Given this list of marker genes FAT3, LARGE1, SLC1A1, ATP8A2, TFAP2A (NCBI Gene Id 95131), RDH13, FJX1, PTPRM, LHX1, SDK2, RS1, FOXN4, AHI1, SDK1, HIPK2, CALB1, MEGF11, CRB1, TFAP2B, DSCAM, HIPK1 (NCBI Gene Id 23323), PROM1, PTF1A, ARL6, TSPAN12, NDP, here is a description of the gene set: species: Homo sapiens Human Gene Set: GOBP_RETINA_LAYER_FORMATION The process in which the vertebrate retina is organized into three laminae: the outer nuclear layer (ONL), which contains photoreceptor nuclei; the inner nuclear layer (INL), which contains amacrine, bipolar and horizontal cells; and the retinal ganglion cell (RGC) layer. Between the inner and outer nuclear layers, the outer plexiform layer (OPL) contains connections between the photoreceptors and bipolar and horizontal cells. The inner plexiform layer (IPL) is positioned between the INL and the ganglion cell layer and contains the dendrites of RGCs and processes of bipolar and amacrine cells. Spanning all layers of the retina are the radially oriented Mueller glia.